Given this list of marker genes NPY, ABAT, SNCA, NR4A2, SLC1A1, ATP7A, MOXD2P, SNCB, SLC6A3 (NCBI Gene Id 6531), SULT1A1, SULT1A4 (NCBI Gene Id 445329), DRD4, GNAT2 (G protein subunit alpha transducin 2), DBH, HTR1A, MAOA, DRD1, PNKD, GPR37, SNCAIP, TH, GRIN2A, ITGB2, DRD3, DDC, MOXD1, HPRT1, VPS35, NPR1, MAOB (monoamine oxidase B), ALDH2, COMT, DRD2, GCH1, TACR3, PDE1B, PRKN (parkin RBR E3 ubiquitin protein ligase), SULT1A3, DAO, TGFB2, NT5DC2, CHRNB2, PARK7, ITGAM (NCBI Gene Id 3684), here is a description of the gene set: The chemical reactions and pathways involving dopamine, a catecholamine neurotransmitter and a metabolic precursor of noradrenaline and adrenaline. Human Gene Set: GOBP_DOPAMINE_METABOLIC_PROCESS species: Homo sapiens